The following is a description of a gene set: Mouse Gene Set: DESCARTES_ORGANOGENESIS_CARDIAC_MUSCLE_LINEAGES species: Mus musculus from publication Cao J, Spielmann M, Qiu X, Huang X, Ibrahim DM, Hill AJ, Zhang F, Mundlos S, Christiansen L, Steemers FJ, Trapnell C, Shendure J (PMID 30787437) Mouse Organogenesis Cell Atlas (MOCA) DE_gene_main_cluster.csv, fold.change>=1.5, qval<0.05, pval<0.05, and this is the list of marker genes: Gata4, Hcfc1r1, Lsmem1, Spats1, Mlip, Styxl2, Csrp3, Tpi1, Cpne5, Smtnl2, Lrrfip1, Hand1, Slc25a4, Ryr2, Myh7b, Mybphl, Oprk1, Lmntd1, Ifitm10, Ppp1r14c, Atp2a2, Csrp2, Hspb7, Usp13, Atp5mc3, Gyg1, Popdc2, Hspb1, Ppp1r3a, Popdc3, Mybpc3, Klhl30, Ankrd1, Cox5a, Cnn1, Gpx3 (NCBI Gene Id 14778), Thbs4, Hectd2os, Ss18l2, Ctcflos, Hspb2, Speg, Myo18b, Des, Mir133a-1hg, Ldb3, Fbxl22, Myh7, Gata6os, 3425401B19Rik, Adprhl1, Smyd1, Obscn (NCBI Gene Id 380698), Myocd, Ttn, Gm10635, Pnkd, Prkaa2, Kcng2, Lmod1, Gm10848, Cited1, Palld, Gm4335, Jph2, Nppa, Hcn4, Tnnc1 (NCBI Gene Id 21924), 5430431A17Rik, Epn3, Tnnt2, Rbpms (RNA binding protein gene with multiple splicing), Rgs6, Rassf5, Rap2c, Mif, Trim54 (NCBI Gene Id 78173), Bmp10, Bmp2, Ndufc1, Tecrl, Dcaf12l1, Gm10118, 6030498E09Rik, Cryab, Tpm1, Dstn, Bves, Myom1, Gm8281, Atcayos, Csrp1, Cacna1c, Gjd2os, Gm12866, Mhrt, Entrep1, Tlx1, Myl4, Idh3a, Nkx2-5, Hdac1-ps, Cmya5, Got1, Fhl2, Txlnb, Nexn, Fbxo40, Ctnna3, Coro6, Ldha, Acta2, Atp5me, Trdn, Irx4, Rnf207, Myl2, Acacb, Gm14769, Cox6a2, Pygm, Lrrc10, Lbh, Pln, Grhl1, A930029G22Rik, Pdlim5, Ptges3l, Rtl8b, Actn2, Tagln, Trim55, Sh3bgr, Cd101, Bex3, Unc45b, Aldoa, Ppp1r13l, Hexim2, Adss1, Alpk2, 4932435O22Rik, Pakap, Gm18066, Trim63, Alpk3, Myl9 (NCBI Gene Id 98932), Apobec2, Atp1b1, Gm12514, Atp5f1b, Lmod2, Smpx, Tnni1, Cacnb2, Atp1a1, Mical2, Ndrg2, Stbd1, Dmd, Lpar3, Vsnl1, Mov10l1, Tnni3, Myh6, Cacna1d (NCBI Gene Id 97919), Mdh1, Gm27211, Fabp3, Nppb, Tnni3k, Actc1, Eno3, Gm15283, Ppp1r3c, Casq1, Usp2, Crip1, Rab1b, 4930512H18Rik, C630028M04Rik, Gata5, Actc1dt, Asb2, Ak1, Cyc1, Crip2, Myl7, Pkp2, Fbxo32, Myl3 (myosin, light polypeptide 3), Pgam2, Rrad, Uqcrfs1, Plppr5, Unc13c, 2900092N22Rik (RIKEN cDNA 2900092N22 gene), Fsd2, Xirp1, Chchd10 (NCBI Gene Id 216112), Sphkap, Gm3636, Rbm20, Tbx20, Slc8a1, Cox6c (cytochrome c oxidase subunit 6C)